The following is a description of a gene set: Human Gene Set: HP_ABNORMAL_CIRCULATING_DEHYDROEPIANDROSTERONE_CONCENTRATION Abnormal circulating dehydroepiandrosterone concentration species: Homo sapiens A deviation from the normal concentration of dehydroepiandrosterone in the circulation., and this is the list of marker genes: ZNRF3, TP53, TXNRD2, TERT, MRAP, PRKAR1A, WNT4, MC2R, CTNNB1, POR, CDKN2A, NNT (nicotinamide nucleotide transhydrogenase), HSD3B2, STAR, CYP17A1